Given this list of marker genes CLIP2 (CAP-Gly domain containing linker protein 2), MSRB2, CXCL8, PHF13, RNF149, SESN3, UBE2D1, GOLM1 (NCBI Gene Id 51280), FRMD5, TTPAL, EPC1, APLF, SCML4, USP31, NAB1, TMEM132B, LIPT2, DLK1, MYRIP, RALBP1, CNIH1, PHGR1, ZNF879, GVQW3, MYO9B, EVC, MPV17L (MPV17 mitochondrial inner membrane protein like), PLEK2, KDM6A, CEACAM1, SNCAIP, EGR1, ACACA, SAP18, LRCH1, SDHC, RHOF, C8orf34, KRTAP4-5 (NCBI Gene Id 85289), ENOSF1, AJAP1, NR4A3, CEP57, CYTIP, STK38, SLC10A7 (NCBI Gene Id 84068), ESR1, PLAAT4 (phospholipase A and acyltransferase 4), TAF4, PPP1R3F, ZNF250, PTGFRN, SGMS1, CYSLTR1, ADAMTS17, UBALD2, GRIN3A, KDM4C, ZRANB1, PABIR2, NPTX2, RASSF2, PPM1M, YWHAG, RBM24, GRIK1, PRRC2C, PLS3, THEMIS, UBXN2B, TOMM22, NCOA4, CENPB, MEOX2, ABITRAM, NSA2, TIFA, MEGF11, TUBGCP4, AKAP10, MFAP4, NFATC1, BAIAP2L1, VEGFB, CDA, here is a description of the gene set: Genes predicted to be targets of miRBase v22 microRNA hsa-miR-4687-3p in miRDB v6.0 with MirTarget v4 prediction scores > 80 (high confidence targets). studied in species Homo sapiens from publication Chen Y, Wang X (PMID 31504780) Human Gene Set: MIR4687_3P